Given this list of marker genes TLR8 (NCBI Gene Id 92553), SLC44A1, KLRK1, DBNL, TMEM43, RAB9A, NDRG1, MYO1G, SREK1IP1, CD300LB, NAGA, FRMD4B, PEAK1, SNX12, TPD52, CFAP210, PTMS, CERK, EP300, SYNJ1, SMCR8, ICAM1, DYRK1A, CRYBG1, TRIM25, UBXN2B, LY9, HLA-B, CATSPERZ, IRF2, RNF135, CCR2, PIK3AP1, NUP98, NLRC5, ADGRG7, ATL3, RFTN1, HERPUD2, CHD9, TET2, CCDC180, IL6R, CASP4, EHD4, FBXO6, STAT2, TAOK3, IL10, GPR141, KAT2B, MUS81 (MUS81 structure-specific endonuclease subunit), HSH2D, PLD4, PTK2B, KDM6A (lysine demethylase 6A), HTR2B, DENND6B, ARHGAP17, USP25, KLF3, NIBAN1, PLEKHA2, IGF1, CYFIP1, SNN, BICRA, OTUD5, LAMTOR3, ITM2B, SASH3, CAP1, IFI30 (NCBI Gene Id 126359), FNIP2, TGFBI, CDS2, TRIM14, SDC4, DAAM1, RNF149, STOM, PDE5A, CBY1, LPIN2, SLC31A2, DSE, CAPN2, P2RY6, BCAR3, ARID1B, NUDT13, MXD1, PPP4R1, VCAN, ITPR1, CRIPT, CD48, SNAP23, DTX2, PARP8, CGAS, RILPL1, SLC27A1, OLFM1, FRMD4A, PDCD6IP, CASP8, ARHGAP10, TIAM1, GTPBP2, CPNE2, PLCL2, MDM2, DHX58, REEP3, SP2, GSAP, RIN2, IFI35, FEM1C (NCBI Gene Id 84463), ARHGEF7, TASL, PACS2, SCYL2 (SCY1 like pseudokinase 2), COPG2, TMEM131, FCGR1A, IL18BP, THEMIS2, SOS2, FAM241A, ADAM8, ARID4A, TAF3, CD300C, STX7, RAB31, GALNT7, SLC11A1, CREG2, F13A1, IL7R, ATP6V0D2, PRCP, HTRA4, DOCK4, BID, CLN6, RIGI, GOLPH3L, WRN, ADAP2, C1orf162, IQGAP2, ZC3H12D, APOBEC1, P2RY14, CALHM6, SIRT1, PFKP, NR1H3, POC1A, FAP, IRF7, CLCC1, DGUOK, AKR1B10, MOB3B, PRKX, DOK3, STX12, HPGDS, SFXN2, ADAR, JAK1, CTTNBP2NL, PLEKHM1, TNFSF10, ANGPTL3, IL15RA, ATP6V1D, OGFR, here is a description of the gene set: studied in species Homo sapiens Genes down-regulated in T cells: CD4 versus CD8. Dendritic cells (DCs) process and present self and foreign antigens to induce tolerance or immunity. In vitro models suggest that induction of immunity is controlled by regulating the presentation of antigen, but little is known about how DCs control antigen presentation in vivo. To examine antigen processing and presentation in vivo we specifically targeted antigens to the two major subsets of DCs using chimeric monoclonal antibodies. Unlike CD8+ DCs that express the cell surface protein CD205, CD8- DCs, which are positive for the 33D1 antigen, are specialized for presentation on MHC class II. This difference in antigen processing is intrinsic to the DC subsets and associated with increased expression of proteins associated with MHC processing. from publication Dudziak D, Kamphorst AO, Heidkamp GF, Buchholz VR, Trumpfheller C, Yamazaki S, Cheong C, Liu K, Lee HW, Park CG, Steinman RM, Nussenzweig MC (PMID 17204652) Human Gene Set: GSE6259_CD4_TCELL_VS_CD8_TCELL_DN